Given this list of marker genes UNC13B, GSX1, CFL2, PPDPF, OSR1, PCDH7, CHST8, PALS1, SP7, FOS, NFYA, GPC3 (NCBI Gene Id 6394), MEX3C, BDNF, NEDD9, TRIM2, EPHB1, FKBP7, PTK2B, GALNT4, PTH1R, STX5, STARD3, ST8SIA2, FEV, CADPS, EVL, HOXB4, PRICKLE3, SLC2A14, BAHD1, MARVELD3, MUC15, APOBR, DNAJC4, TOMM20, KCNQ5, PHF21B, CSMD3, IFRD2, ZIC4, FAM110A, LIMK2, CD40, SERPINI1, TLCD4, TCF4, EPN3, DPF3, ASIC2, PPARG, ZC3H11A, ZBTB16, IGF2BP1, CLDN18, POU3F2, BRPF1, SLC16A6 (NCBI Gene Id 9120), PAFAH1B1, SAMD1, LSG1, SOX10, FSTL1, EMC3, HOXB5, PRIM2, DTNA, ESRRG, PER2, ETV5, AKAP7, PHACTR3, IP6K2, SESN3, CHODL, DMD, CHD6, TSPAN13, RGL2, RORC, HOXB2, CTNND1, CALCOCO1, NR2F1, RASAL2, HOXB3, ATF7IP, NTRK2, RPL13A, MOSPD1, GOLGA7, ABCA6, KCNK10, POC1B, SYT6, UBE2A, MAML3, ERI1, NYAP1, NUP54, IL27, CRB1, FRMD4A, PPP2R5C, PURA, SLC20A1, B3GALT5-AS1, A1CF, DEGS2, PFKFB3, BCL6, LRRTM4, HOXC4, TGFBR1, SCUBE3, ECHDC2, C12orf42, MAML2, ZNF646, BRICD5, XPO1, RARB, SMPX, PHGDH, TIMM9, KLHL3, PHOX2B, ZFPM2, RNF11, CITED2, SLCO2B1, RNF122, OLFM2 (olfactomedin 2), PACRG, TP63, VASN, KRT23 (NCBI Gene Id 56668), LRRTM1, ST6GAL1, CDYL2, HIPK1, PRKN, MN1, NFIB, STMN2, SLCO3A1, KIAA0586, ATXN7L1, PALS2, TCF7L2, PMP22, LMO3, COL10A1, LSAMP (NCBI Gene Id 4045), EIF4G1, C12orf50, RTN1, FAM107A, OARD1, PPP2R2B, FGF9, IGSF21, TOB1, PRKCH, SLC39A2, POLR3GL, SHCBP1L, MARCKS, GPX1, LUC7L3, MISP, NDUFA13, ZNF184, PLEC, ZNF668, CIMAP1C, CDC20, SERBP1, KCNQ1DN, ADCY8, RBMS3, EGFR, FAM78A, TCF12, PTCH1, LOX, AQP5, TEX47, FBXL22 (F-box and leucine rich repeat protein 22), MGLL (NCBI Gene Id 152009), LASP1, ASCC3, JADE1, ZBTB32, TCTA, SDC1, ZMYND8, WBP4, DLL1, CCDC91, RPS6KB1, ERF, MEIS2 (NCBI Gene Id 56908), NFKBIA, DRD5, EPB41L3, AGER, NOL4L, CALM2, PPP3CA, GLT8D2, TBX5, GRIK3, IGF1, HOXC10 (homeobox C10), SEMA6D, NPVF, TSPYL2, ING3, HTR7, DHRS3, HOXC12, CCND1, UBR3, MIR137HG, PPP1R3C, KRT84, GAS2, DNER, RNF220, ZNF143, EIF5, LUC7L2, ADAMTSL1, ELK3, KCNJ10 (NCBI Gene Id 3766), NMBR, CSF2, SDCCAG8, ATP5MC2, KCNK9, FZD10, UNC13D, CACNA2D2, RHOA (ras homolog family member A), EHBP1, TRIM8, ELAVL4, PCNX1, EN1, KRT8P41, TNKS2, RUNX1T1, FLNC, HOXA10, GRID2, ADGRL2, FOXP2, ETHE1, CLDN2, MID1IP1, TBCC, HIVEP3, DUSP4, CCL22, here is a description of the gene set: Human Gene Set: PAX2_02 species: Homo sapiens Genes having at least one occurrence of the motif NNNAAASNN in the regions spanning 4 kb centered on their transcription starting sites. This matches the PAX2 transcription factor binding site V$PAX2_02 (v7.4 TRANSFAC).